Given this list of marker genes Ywhah, Zfyve27, Neurog1, Gprc5b, Nkx6-1, Rock1, Acsl6, Camk2g, Lrp2, Nyap2, Hes1, Fgfr3, Mir212, Stk24, Enc1, Avil, Mir133b, Mgll, Poc5, Fbxo41, Lrrk2, Tfap4, Rab11a, Ube4b, Ptpn1, Fezf2, Prdm8, Dbnl, Cxcl12, P3h1, Mir132, Ddx56, Mir124a-1, Ugdh, Apbb1, Ptprz1, Tox, Lhx3, Adcyap1, Tmem67, Nrcam, Syt17, Rabl2, C1ql1, Arhgap4, Robo3, Lama2, Dkk1, Runx1, Drd2, Cthrc1, Dip2b, Vax2, Ulk4, Sclt1, Pten, H2-K1, Cacng7, Creb1, Farp2, Dhfr, Ptprm, Mef2c, Myo3a, Cdhr1, Fbxw8, Rgma, Bloc1s1, Tiam1, Nedd4l, Creb3l2, Ercc6, Fscn2, Bloc1s2, Actbl2, Zic2, Nbl1, Adgrf1, Adam17, Picalm, Lifr, Nr4a2, C9orf72, Cul7, Crk, Vax1, Ncs1, Spag9, Sema3c, Trim46, Akap5, Scrib, Nlgn1 (neuroligin 1), Dynlt1f, Eef2k, Gnat2, Slc38a8, Evl, Vegfa, Rap2a (NCBI Gene Id 76108), Abi2, Prph2, Rap1gap2, Sema3g, Hnrnpk, Kif5a, Lonrf2, Rgs2, Mef2a, Tsc2, Gata3, Map3k13, Tsku, Snap91, Ptch1, Tctn1, Plxna1, Tlx2, Slitrk3, Dicer1, Fstl4, Usp33, Fyn, Ephb1, Rtn4rl1, Pbx1, C1qa, Epha6, Numb, Pum2, Myo5b, Sirt1, Rp1, Fmr1, Anks1, Gfi1, Hprt1, Tshr, Gbx2, Ntm, Nr4a3, Bmpr1b, Mapt, Uhmk1 (U2AF homology motif (UHM) kinase 1), Crp, Tbc1d24, Prag1, Spast, Il1rapl1, Gm2990, Syt1, Lhx6 (LIM homeobox protein 6), Garem2, Hap1, Sema4f, Nox1, Tspan2, Efnb2, Uqcrq, Arc, Lhx2 (NCBI Gene Id 16870), Cnga3, Alkal2, Cdh2, Cntn2, Nptxr, Sec24b, Tmem132e, Tnfrsf12a, Tprn, Sema3a, Lingo1, Islr2, Grcc10, Irx5, Chat, Dag1, Nefl, Zfp804a, Rorb, Mypn, Lpar1, Chrna3, Hes5, Ttc3, Pak2 (p21 (RAC1) activated kinase 2), Pitpna, Mrtfa, Srf, Tnr, Nr2e3, Sema4a, Ift140, Fry, Srgap2, Mtor, Prdm12, Etv4, Atp8a2, Ppp1r12a, Pbx4, Arid1b, Dlg2, Ust, Wnt7a, Dpysl5, Stmn2, Rac1, Plk2, Celsr3, Ift88, Spr, Ptbp1, Mboat1, Fshr, Plaa, Nphp4, Nhlh2, Nckap1, Myt1l, Rpl4, Gak, Itga3, Tmem106b, Cd44, Abl2 (ABL proto-oncogene 2, non-receptor tyrosine kinase), Mag, Edn2, Map6 (microtubule-associated protein 6), Lrp4, Map1a, Mycbp2, Otogl, Bloc1s6, Trak2, Vsx1, Gap43, Rab13, Eif2b2, Cep290, Samd7, Tecta, Plxnc1, Klf4 (NCBI Gene Id 269540), Tet1, Rap1a, Mfsd8, Elmod3, Cdk16, Rnf6, Tenm1, Runx1t1, Prickle2, Mul1, Ssna1, Ift20, Slc25a46, Mir183 (microRNA 183), Crtc1, Xlr3b, Dpysl2, Prdm1, App, Ptprd, Carm1, Atg7, Btbd3 (BTB domain containing 3), Rtn4rl2, Ripor2, Lzts3, Megf9, Spag6, Wdr47, Pbrm1, Flrt3, Pbx3, Braf, Bsg, Rims1, Smn1, Grid2 (glutamate receptor, ionotropic, delta 2), Map1b, Spg21, Foxb1 (NCBI Gene Id 64290, forkhead box B1), Rapgef2, Npy, Hecw1, Alcam, Brsk1, Lamb2, Slc4a7, Dtnbp1, Agbl4, Prkcsh, Neurod2, Insm1, Pak3, Itpka, Tanc2, Slitrk6, Lama1, Pafah1b1, Ikbkb, Dnm3, Prkca, Mfn2, Nr2e1, Ntn3, Trpc6, Kcnq1, Lmo4, Caprin1, Lst1, Ppfia2, Tenm3, Hexa, Cdnf, Nek3, Brsk2 (NCBI Gene Id 75770), Rab17, Ephb3, Ptprv, Cfap418, Ctnnd2, Rpgrip1l, Mir9-2, Atf5 (activating transcription factor 5), Trpv4, Myo9a, Nrl, Abi1, Pdlim5, Rhoa, Notch3, Cx3cl1, Gpr37, Dbndd2, Rasal1, Rab35, Tsc1, Cers2, Lrrc7, Clu, Rab29 (NCBI Gene Id 226422), Ptk7, Areg, Sh3glb1, Mir9-1, Rac3, Numbl, Szt2, Apbb2, Neurog2, Mmp2, Nfatc4, Btg2, Wdr5 (NCBI Gene Id 98832), Map2k2, Micall1, Itpr1, Kcnma1, Olig1, Thrb, Ap2a1, Npr2, Whrn, Ascl1, Rdh13, Itm2c (NCBI Gene Id 98594), Pak6, Golga4, Bicdl1, Grip2, Serpini1, Chrna7, Phox2b, Pcdh15, Epor, Klf7, Ifrd1, Minar2, Sin3a, Bmpr2 (NCBI Gene Id 98751), Frmd7, Cdc20 (NCBI Gene Id 98038), Rpgrip1, Mir124a-2, Vim, Tulp1, Slc44a4, Snx3, Kidins220, Septin7, Foxp1, C3, Htra2, Neu4, Sall3, Rit2, Fkbp4, Syt2, Cntnap2, Edn3, Chrnb2, Lamb1, Nme1, Tubb3, Ptprt, Nrtn, Kndc1, Jak2, Ctnna2, Smo (NCBI Gene Id 319757), Clasp2, Kcnb1, Ep300, Tpbg, Camk2b, Svbp, Arhgap44, Cntn4, Klk6, Tor1a, Apoa1, Pdzd7, Kcna1, Mgarp, Slitrk4, Plp1, Lgi4, Fbxo45, Celsr2, Sema7a, Prickle1, Dab2, Enpp1, Crppa, Bhlhe23, Mtmr2, Tnik, Nlgn2, Pls1, Sema3e, Ift56, Syn1, Dcdc2a, Or10a4, Reln, Arf1, Gla, Prkci, Cflar, Pcare, Spire1, Samd4b, Cd3e, Ngb, Grk1, Ptprk, Prrx1, Ahi1, Map1s, Vldlr, St8sia2, Evx1, Gpx4, Efhd1, Pou4f2, Camk2a, Stk11, Kifc2, Adm, Magi2, Tbce, Ncam1, Gas7 (growth arrest specific 7), Snx1, Unc5a, Tiam2, Abl1, Shtn1, Prex1, Bcl11b, Gfap, Zfp365, Dcx, Cspg4, Cfl1, Pde6c, Plxnb3, Stx1b, Llgl1, Nptx1, Gpm6b, Rpl24, Khdc3, Wnt5a, Stx3, Trim67, Kif5b, Prtg, Amigo1, Arf4, Gdf7 (NCBI Gene Id 238057), Mfn1, Snap25, Sema6d (sema domain, transmembrane domain (TM), and cytoplasmic domain, (semaphorin) 6D), Bdnf, Clmn, Chn1, Atf1, Ctnnb1, Galr2, Dscam, Dab2ip, Mov10, Gas1, Dbn1, Wnt3, Acte1, Tunar, Gata2, Cntn6, Nptn, Scarf1, Apoa4, Lhx4, Nr3c1, Fkbp1b, Ppp2r5b, Nin, Bhlhb9, Drd1, Fat3, Lgr4, Csmd3, Ptn (NCBI Gene Id 19242), Pcdhac2, Srrm4, Bmp5, Etv1, Efnb3, Fgf13, Crabp2, Stk25, Fzd2, Sema4c, Mfsd2a, Washc5, Olig2 (NCBI Gene Id 50913), Pak4, Mecp2, Caprin2, Edn1, Cck, Kif3c, Fezf1, Robo1, Syngap1, Ddr1, Tbcd, Epha8, Mdm2, Cdkl3, Gsk3a, Mapk8, Ndel1, Mdk, Nkx2-9, Cd2ap, Dzank1, Fzd4, Sema4b, Nexn, Dact1 (dishevelled-binding antagonist of beta-catenin 1), Metrn, Zpr1, Pqbp1, Lhx9, Mcf2 (mcf.2 transforming sequence), Ulk2, Efna3 (NCBI Gene Id 99908), Ngfr, Alkbh1, Sult4a1, Gli2, Myot, Plxna4, Lrig2, Dab1, Trip11, Crebbp, Cbfa2t2, Negr1, Unc13a, Ntn4, Slc23a2, Pjvk (NCBI Gene Id 381375), Efna5, Slc11a2, Neurog3, Sdc4, Inppl1, Efna4, Drgx (NCBI Gene Id 239019), Spg11, Afg3l2, Cul4b, Pcp4, Impact, Pax6 (paired box 6), Ush1c, Nfe2l2, Cntn1, Ugt8a, Nck2, Ptprq, Zswim6, Ttc36, Kif3a, Trpv2, Reg1, Zmynd8 (zinc finger, MYND-type containing 8), Eif2ak4, Nfib, Alk, Rnd2 (Rho family GTPase 2), Sarm1, Ppp1r9a, Smurf1, Grn, Lrp12 (NCBI Gene Id 239393), Zdhhc15, Dleu2, Gdpd5, Unc5d, Prmt3 (protein arginine N-methyltransferase 3), Mink1, Nova2, Cdk5r2, Lpar3, Ywhaz (NCBI Gene Id 68643), Lmtk2 (lemur tyrosine kinase 2), Cdc42, Rab3a, Kcnip2, Tnc, Cxcr4, Tbc1d23, B4gat1, Prmt1, Fzd3, Sema6a, Pak1, Rnd1, Fat4, Ntrk2, Sfrp2, Cckar, Neurl1a, Clrn2, Palm, Megf8, Ophn1, Robo2, Dhx36, Ctnna1, Hoxa1, Ptk2b, Llph, Ulk1, Strc, Ntf5, Cit, Epb41l3, Lamc3, Lamb3, Efhc2, Ppp1r12b, Unc5c, Cspg5, Pbx2, Skil, Ext1, Adcy10, Spock1, Flna, Atp8b1, Ogdh, Neurod4, Adnp, Fgfr2, Gdnf, Cdk5r1, Ankrd24, Dst, Itsn1, Alms1, Myh10, Slitrk2, Slit1 (NCBI Gene Id 226119), Fes, Wee1, Nlgn3, Miat, Ap5z1, Cib1, Cntn3, Ptprg, Vangl2, Nog, Mnx1, Wasf1 (WASP family, member 1), Mir96, Clrn1, Agrn, Fcgr2b, Als2, Gprin3, Rab10, Sptbn4, Bmp7, Neurod1, Trim32, Syt4, Myo6, Syt3, Ndn, Mapk8ip2, Ntrk1, Ihh, Mir9-3, Tenm4, Camsap1, Cpne1, Boc, Dio3, Zfp335, Nell2, Ctf1, Neurod6, Olfm3, Asap1, Nyap1, Efna2, Ugcg, Ppp1r12c, Atp7a, Dlg4, Shc1, Naglu, Erbb2, Ablim1, Ccdc39, Htt, Tenm2, Stmn1, Olig3, Cpeb1, Cd24a, Paqr3, En2, Katnb1, Gprin2, Spag6l, Atg16l1, Auts2, Fzd1, P2ry2, Dnm2, Xylt1, Ncdn, Casp6, Otx2, Plppr4, Tomt, Mturn, Pdgfb, Disc1, Ythdf1, Rab21, Sema5a, Cpne5, Kif1a, Ednrb, Slc30a1, Retreg3, Thoc2, Bex1, Abitram, Camsap2, Agtpbp1, Zfp296, Nkx2-1, Dvl2, Hcn1, Nrp2, Egfr (NCBI Gene Id 13649), Egr2, Usp21 (NCBI Gene Id 30941), Fgfr1, Mtr, Dnm1l, Mark1, Ank3, Cntf (ciliary neurotrophic factor), Cabp4, Acap3, Nckipsd, Ptprf, Hspb1 (heat shock protein 1), Hecw2, Hspa5 (NCBI Gene Id 99198), Gldn, Zc4h2, Th, Farp1, Arhgap32, Spart, Bhlha15, Acsl4, Ube3a, Slc4a10, Ppp3ca, Dvl1, Rb1, Cdk5, Cecr2, Dynlt1c, Lrp8, D130043K22Rik, Shank1, Stxbp1, Igfals, Ndufs4, Lhx8, Ttl, Nedd4, Tuba1a, Hgf, Shank3, Actr2, Camk1d, Gba2, Afdn, Ptprh, Pld2, Cdh1, Sdc2, Gabrb2, Hdac6, Sema3d, Iqsec1, Rtn4r, Rab8a, Rest, L1cam, Kremen1, Diaph1, Plxnb2, Cyfip1, Zmiz1, Map2, Adora2a, Grm7, Ephb2, Arfgef1, Serpine2, Atoh1 (NCBI Gene Id 11921), Camk1, Lmx1b, Onecut2, Klk8, Dscaml1, Lmx1a, Sipa1l1, Pou4f3, Top2b, Katna1, Map2k1, Ube2v2, Cask, Gja1, Cdh23, Adcy1, Atp9a, Inpp5j, Lep, Vrk1, Crb2, Sema5b, Anapc2, Arhgef28, Nsmf, Fev, Sgk1, Slc1a3, Dync1i2, Vps54, Tnxb, Ilk, Xk, Rock2, Mapk6, Twf1, Adarb1, Gbx1, Arhgap35, Ptprs, Neu1 (neuraminidase 1), Dclk2, Arx, Efna1, Bcl2, Cux2, Dubr (NCBI Gene Id 68190), Kif5c, Gdi1, Bloc1s3, Grin1, Sfrp1, Lama3, Kat2b, Dip2a, Stau2, Gnat1, Plxnd1 (plexin D1), Met, Draxin, Pip5k1c, Becn1, Obsl1, Akt1, Foxg1, Hdac2 (NCBI Gene Id 28131), Ncam2, Kcnq3, Col25a1, Tdp2, Uba6, Itga1, Postn, Rom1, Smad4 (NCBI Gene Id 28063), Actb, Elavl4, Zdhhc17 (NCBI Gene Id 320150), Flot1, Atl1, Setx, Mbp, Grxcr2, Rtn4, Igf1r, Lzts1, Olfm1, Ptpn9, Atxn2, Grin3a, Mapk8ip3, Mark2, Wnt7b, Ptprj, Kdr, Barhl2, Dlg5, Fgf8, Ndnf, Psd, Trak1, Mir200c, Fam168b, Nme2, B4galt6, Sema3b, Mrtfb, Cdh4, Nckap1l, Kif13b, Wls, Myo7a, Fn1, Abi3bp (ABI family member 3 binding protein), Lrp6 (NCBI Gene Id 77387), Mylip, Hoxa2, Slitrk1, Ryk, Golga2, Nrn1l, Crtac1, Ltk, Folr1 (folate receptor alpha), Or8a1b (olfactory receptor family 8 subfamily A member 1B), Macf1, Nrp1, Enah, Cyfip2, Sema4d (NCBI Gene Id 20354), Phgdh, Sh3gl2, Pmp22, Tmem30a, Nr2f1, Adam10, Clstn3, Actg1, Ngf, Arf6 (ADP-ribosylation factor 6), Bhlhe22, Mir182, Gsk3b, Hs6st1, Bcl7a, Cnr1, Mapkapk5, Unk, Pacsin1, Fbxo7, Amigo3, Rere, Dcc, Trpc5, Ush1g, Cntn5, Cpeb3, B4galt5, Isl1, Atp1b2, Ehd1, Atat1, Tspo (NCBI Gene Id 12257), Sez6, Ist1, Dmd (NCBI Gene Id 93863), Wnt3a, Septin2, Opa1, Tsc22d4, Sdk1, Nck1, Lgals1, Cc2d1a, Rapgef4, Lgi1, Ntn5, B2m, Cd38, Actr3, Stmn3, Isl2, Neo1, Chl1, Pla2g3, Ranbp1, Acp4, Prkn, Prkcz, B3gnt2, Hey1, Gfra1, Il15ra, Gpc2, Shox2, Myo3b, Alkal1, Tmc1, Qki, Styxl1, Lrp1, Lyn, Flrt2, Tfap2a, Fbxo31, Nrxn1, Slit2, Mir200b, Tnfrsf21, Taok2, Gabrb3, Ostn, Ntrk3 (neurotrophic tyrosine kinase, receptor, type 3), Ephb6, Rapgef1, Cacna1f, Tgfb2, Dlx5 (distal-less homeobox 5), Lama5, Ece1, Rp1l1, Apoe, Ndp, Itga6, Cxcl5, Hoxd9, Bmp4, Eif4g2, Dpysl3, Jun, Myo16, Itsn2, Dguok, Cyth2, Epha10, Diaph2, Slit3, Ptpn5, Ager, Nphp1, Scyl1, Ptpru, Rnf220, Vcl, Lhx1, Agt, Dock10, Igsf9, Plppr5, Actl6b, Sema3f, Triobp, Id2, Scyl2, Prkg1, Fez1, Map4k4, Uchl1, Ankrd27, Ache, Vps13a, Kdm1a (lysine (K)-specific demethylase 1A), Crkl, Fut9, Adcy6, Pou3f2, Emx1, Zfp212, Bbs1, Git1, Nfix, Xbp1, Nrep, Map4, Bcan, Fbxo38 (F-box protein 38), Fas, Arhgef25, Clip1, Lif, Lamc2, Ret, Camsap3, Gfra3, Vasp, Sod1, Itgb1, Atp2b2, Rrn3, Skor2, H2-D1, D16Ertd472e, Shh, Fam151b, Cdkl5, Slc9a6, Stxbp5, Gabrr2, Samd11, Kif26a, Samd14, Ntng2, Dynlt1b, Fig4, Otog, Tnn, Sema6c, Mir200a, Fxn, Slc12a5, Bloc1s4, Taok1, Sema6b, Ntn1, Tug1, Sema4g, Ankrd1, Prex2, Hoxd10, Ptpn11, Ucn, Snapin, Epha5, Ppp2r5d, Ccr5, Cdh11, Sphk1, Artn, Tbx6, Omg, Nherf1, Dixdc1, Notch1, S100a9, Plxnb1, Ss18l1, En1, Mapk9, Smim45, Shoc2, Ptk6, Gngt1, Adgrv1, Gpm6a, Zbtb18, Ednra, Raph1, Id1, Cdc27, Apc, Adgrb3, Il2, Phactr1, Usp9x, Matn2, Efemp1, Tbr1, Cngb1, Scarb2, Mir124a-3, Ddr2, Il6, Pals1, Nectin1, Grip1, Ark2c, Crb1, Parp6, Stmn4, Arhgap33, Epha3, Fryl, Rasgrf1, Kif21a, Rtn4ip1, Kif20b, Chodl, Mpdz, Prkd1, Atcay, Scyl3, Lhfpl5, Kcnq2, Mt3, Ptk2, Cobl, Abi3, Borcs7, Bbs4, Ptpro, Tubb2b, Cdkn1c, Zeb2, Strn, Trp73 (NCBI Gene Id 22062), Ccdc88a (coiled coil domain containing 88A), Crmp1, Mir376a, Scn11a, Cnp, Lrrc4c, Trpm1, Foxd1, Plk5, Ndrg4, S100b, Cfh (complement component factor h), Cpne6, Ubb, Ppp1r9b, Itga4, Aplp1, Foxo6, Aplp2, Pou4f1, Taok3, Ntng1, Gprin1, Thbs4, Dynlt1a, Ngef, Rpgr, Unc5b, Sox1, Baiap2, Serpinf1, Plxna3, Epha7, Rnf157, Clic5, Arsb, Brinp1, Epo, Apod, Atoh7, Vapa, Nanos1, Mks1, Rbfox2, Wasl, Nrdc (nardilysin convertase), Kel (NCBI Gene Id 23925), Micall2, Upf3b, Trio, Rtca, Pias2, Emb, Kifbp, Inpp5f, Atxn10, Csf1r, Thoc2l, Rufy3 (NCBI Gene Id 72186), Igf2bp1, Mfrp, Gli3, Nefh (neurofilament, heavy polypeptide), Dock7, Jade2, Adamts1, Slc39a12, Nrg1, Cacna1a, Flrt1, Ntf3, Ift27, Srcin1, Epha4, Trappc4, Gabra5, Nf1, Rims2, Gabrb1, Kank1, Minar1, Sf3a2, Twf2, Cntnap1, Wdr36 (WD repeat domain 36), Lamc1, Hdgfl3, Limk1, Gorasp1, Hand2, Htr7 (NCBI Gene Id 15566), Nfasc, Iqgap1, Ghrl, Aurka, Pla2g10, Thy1, Bag5, Tmem108, Secisbp2, Ttc8, Efnb1, Mob2, Herc1, Cpne9, Pitx3, Casp3, Dvl3, Dennd5a, Nrn1, Sod2, Vash2, Kalrn, Marcks (myristoylated alanine rich protein kinase C substrate), Bloc1s5, Arl3, Grxcr1, Dclk1, Slitrk5, Scn1b, Runx3, Kirrel3, Myoc, Wdpcp, Alg10b, Klhl1, Nr2f6, Cux1, Psen1, Cttn, Dgkg, Bcl11a, Gnaq, Ezh2, Nefm, here is a description of the gene set: Mouse Gene Set: GOBP_NEURON_DEVELOPMENT The process whose specific outcome is the progression of a neuron over time, from initial commitment of the cell to a specific fate, to the fully functional differentiated cell. species: Mus musculus